The following is a description of a gene set: The regrowth of axons outside the central nervous system (outside the brain and spinal cord) following an axonal injury. species: Homo sapiens Human Gene Set: GOBP_PERIPHERAL_NERVOUS_SYSTEM_AXON_REGENERATION, and this is the list of marker genes: APOA4, MAP1B, MIR221, MMP2, TNC, MIR222, TSPO, NEFL, CERS2, APOD